Given this list of marker genes CEP350, EPS8L2, DNAJC4, STXBP3, PPP2R5A, RIPK3, PCBD1, SUMF1, UBR4, NGFR, RBM17, SLC35C2, NDRG4, KRTCAP2, SLU7, XCR1, TLR7, KRT31, FBH1, S100A8, C4orf19, DPCD, NPR1, PMFBP1, TREM2, NFIL3, PGLYRP1, LPIN2, USB1, HFE, ANKS1A, NREP, RABGAP1L, SLC37A1, FAM117A, SEPTIN10, KALRN, PCCA, PXMP2, KHDRBS1, DNAJC12, BLTP1, RAD51AP1, SUDS3, SEBOX, NXN, SSBP1, KLF2, MTBP, UNC50, RGL1, ZBTB20, CRBN, TTC39B, CLDND1, HIGD1C, TNFRSF12A, FGF13, GADD45B, QPCT, PACS2 (phosphofurin acidic cluster sorting protein 2), TBC1D1, AARSD1, POLR3GL, UBXN2B, CUTC, MRPL13, NUDT9, BCL2L14, TTC16, VPS37B, SEMA4B, EPC1, AP1S2, C8orf33, ANGPTL2, EHD2, NETO1, APBB1, RNASET2, RCOR1, RAB13, CAMK2D, EDN1, SUN2, CLDN23, TLE4, OGFR, STOM, CMIP, NUP88, TRIM6, C6orf62, C3orf62, TM2D2, CCL5, TAMALIN, RABEPK, ATP6V1D, TMEM209, TAX1BP1, HDAC5, PCK2, PTGDS, ARHGAP9, SERHL2, SLC7A8, WBP4, PTPN18, FAP, KCTD12, PLCG2, SART3, HSCB, MPZ, ELK4, CBX4, PDLIM1, RD3, PIH1D1, RAG1, GRN, POU3F2, TPM2, ADGRE5, MTHFS, RBMS2, EXOC4, OSBPL9, HMG20B, GAD2, TOB1, AVL9, SLC35B2, SLC15A4, N4BP2L1, PFKFB3, TSPO, ANAPC13, GLRX2, UQCRC2, FBLIM1, CBY2, ABHD16A, HMGB1, CRISPLD1, BCL2, CHST15, STAG2, DAGLB, FGD1, ITPK1, CWC22, TEP1, SPTBN1, ITM2B, UBE2R2, CD5L, IGFBP5, LRRC8C, FGF21, SERINC3, SLC51A, DAPP1, CASP9, KARS1, PRCP, DNMT3A, XDH, CUL4B, WNT8A, SMAD4, RHOH, TMEM176B, FNBP4, ETV6, DNAJC5B, NCAN, CSNK1D, LAT2, MED12, NAAA, CPNE3, CAMK1D, NUB1, EFS (NCBI Gene Id 10278), SOS1, ITPRID2, DPEP3, MRC1, PDCD10, DOCK1, RNF214, CALHM2, AURKA, MCM10, SMAGP, HOXB13, UBE2D1, AEBP2, here is a description of the gene set: Genes up-regulated in comparison of dendritic cells (DC) stimulated with poly(I:C) (TLR3 agonist) at 6 h versus DC cells stimulated with Pam3Csk4 (TLR1/2 agonist) at 6 h. species: Homo sapiens mouse primary BMDCs were stimulated with tlr ligands and gene expression changes were profiled on Affymetrix arrays from publication Amit I, Garber M, Chevrier N, Leite AP, Donner Y, Eisenhaure T, Guttman M, Grenier JK, Li W, Zuk O, Schubert LA, Birditt B, Shay T, Goren A, Zhang X, Smith Z, Deering R, McDonald RC, Cabili M, Bernstein BE, Rinn JL, Meissner A, Root DE, Hacohen N, Regev A (PMID 19729616) Human Gene Set: GSE17721_POLYIC_VS_PAM3CSK4_6H_BMDC_UP